The following is a description of a gene set: species: Homo sapiens Human Gene Set: GSE32034_LY6C_HIGH_VS_LOW_MONOCYTE_UP from publication Gautier EL, Chow A, Spanbroek R, Marcelin G, Greter M, Jakubzick C, Bogunovic M, Leboeuf M, van Rooijen N, Habenicht AJ, Merad M, Randolph GJ (PMID 22855714) Genes up-regulated in Ly6C monocytes: high versus low. PPARγ is known for its anti-inflammatory actions in macrophages. However, which macrophage populations express PPARγ in vivo and how it regulates tissue homeostasis in the steady state and during inflammation is not completely understood. We show that lung and spleen macrophages constitutively expressed PPARγ, while other macrophage populations did not. Recruitment of monocytes to sites of inflammation was associated with induction of PPARγ as they differentiated to macrophages. Its absence in these macrophages led to failed resolution of inflammation, characterized by persistent, low-level recruitment of leukocytes. Conversely, PPARγ agonists supported an earlier cessation in leukocyte recruitment during resolution of acute inflammation and likewise suppressed monocyte recruitment to chronically inflamed atherosclerotic vessels. In the steady state, PPARγ deficiency in macrophages had no obvious impact in the spleen but profoundly altered cellular lipid homeostasis in lung macrophages. Reminiscent of pulmonary alveolar proteinosis, LysM-Cre x PPARγflox/flox mice displayed mild leukocytic inflammation in the steady-state lung and succumbed faster to mortality upon infection with S. pneumoniae. Surprisingly, this mortality was not due to overly exuberant inflammation, but instead to impaired bacterial clearance. Thus, in addition to its anti-inflammatory role in promoting resolution of inflammation, PPARγ sustains functionality in lung macrophages and thereby has a pivotal role in supporting pulmonary host defense., and this is the list of marker genes: REEP3, TMEM163, BLOC1S6, HLA-DOB, CABYR, NUDT4, BMP5, MYO1G, NRM, SLC25A24, ARL4D, DPYSL3, IL17A, CRTAP, TNFRSF21, CLBA1, GPR83, RORA, GZMB, ITGA2 (integrin subunit alpha 2), PGLYRP1, RUNX2, ICOS, STAG3, POLH, SERPINE2, HSD11B1, PLAUR, ADAM19, HTR4, CDC42EP3 (CDC42 effector protein 3), TH, STAT4, ATP2A3, HOPX, PRDM1, CDH3, FMO3, NUPR1, IL10, ENTPD4, CIITA, IL13, IL5RA, NHSL1, NRG4, STEAP4, HYAL2, MAP2K1, XIST, TRPV2, ANXA4, DRAM2, DMC1, P2RX5 (NCBI Gene Id 5026), ACP3, EEF1A2, VIM, MTFR1, SLAMF7, RRAGA, MMP10, ANXA2, ETV4 (NCBI Gene Id 2118), FCGR2B, RAB3D, ST3GAL6, PRSS16, CENPF, CACNA2D3, AK3, DNMT3A, AQP9, TFAP2A, KRTAP15-1, FOXA1, C5orf22, LPIN1, GRIA3, PRPS2, RPS6KA1, KCNE2 (potassium voltage-gated channel subfamily E regulatory subunit 2), ITGAX, CCR2, KLRK1, CASP4, C8G, SORD, METRNL (NCBI Gene Id 653506), KCNJ10, PLEKHF2, SPATA6, SLC37A2, WLS, ERN1, MCOLN3, TCF3, IFNG, WNT16, GM2A, SERPINB6, C6orf89, PTPRO, CCDC85A, HILPDA, PA2G4, TMEM41B, PODXL, NFATC1, CD79A, TMEM151B, FZD9, IL1RL1, TNFSF10, CRB1, WDFY2, ITGB2, TMEM263, APOH, GNG10, BMP15, CCL4, SGK3, EBPL, REEP5, LCN2, SIX2, ADAM12, TEK, FKBP9, TMEM98, PDIA4, SPIN4, ECHDC3, ACSL1, TPRG1L, NEDD1, SEMA7A, ZYG11A, CRHR2, WNT10B, BHLHE40, POLA1, RHPN2, IER3, SLC12A3, CCL22, CEP15 (centrosomal protein 15), CEMIP2, DNASE1L3, GDF3, GLUD1, CFAP97, CALCB, MTFR2, GAS7, CASP1, SERPINB11, TFF3 (NCBI Gene Id 7033), TLE3, MED14, AAGAB, VSNL1, ADAT1, ITM2B, ACTG1, RLN1, RAP1B, PABPC1, SCGN, CREB3L3, TESMIN, GBX2, NSDHL, PTH2, DPH6, MID1IP1, ACYP2, DDIT4L, ZCCHC18, THTPA, GABARAPL1, DOCK5, CSGALNACT1, SOWAHC (sosondowah ankyrin repeat domain family member C), ASRGL1, CDKN2C, TM6SF1, FGR, RBMS1, SPMIP5, YIPF1, ACLY, ACTB, DNAJC1, EFHD1, RASGRP1, LIPC, CCL11, USP8